The following is a description of a gene set: Dysostosis multiplex Human Gene Set: HP_DYSOSTOSIS_MULTIPLEX studied in species Homo sapiens, and this is the list of marker genes: SGSH, GNE, SUMF1, NEU1, GUSB, MAN2B1, AGA, FUCA1, FGFR1, GNS, GALNS, GLB1, IDS, CTSA, GNPTAB, NAGLU, ARSB, KRAS, HGSNAT, VPS33A, IDUA, GNPTG, LYSET